The following is a description of a gene set: Human Gene Set: GOCC_MATRIX_SIDE_OF_MITOCHONDRIAL_INNER_MEMBRANE studied in species Homo sapiens The side (leaflet) of the mitochondrial inner membrane that faces the matrix., and this is the list of marker genes: NDUFAF5, COA8, DNAJC19, BDH1, AMBP, PAM16, NOA1